The following is a description of a gene set: Mouse Gene Set: GOBP_PRIMARY_AMINO_COMPOUND_BIOSYNTHETIC_PROCESS studied in species Mus musculus The chemical reactions and pathways resulting in the formation of primary amino compound., and this is the list of marker genes: Cyp2d22, Tph2, Tph1, Aldh2, Gch1, Ddc, Fev